The following is a description of a gene set: Human Gene Set: ETS_Q4 studied in species Homo sapiens Genes having at least one occurrence of the motif ANNCACTTCCTG in the regions spanning 4 kb centered on their transcription starting sites. This matches the ETS1 transcription factor binding site V$ETS_Q4 (v7.4 TRANSFAC)., and this is the list of marker genes: TGFB3, CNOT10, CANX, PPP1R9B, NME2, GAB2, ARAP1, CD247, GJA5 (NCBI Gene Id 2702), TEAD3, ACSL5, TNS2, VAV1, ELMO1, CSAD, ZMYND8, DAB2IP, KLF13, CORO1A, DOCK11 (NCBI Gene Id 139818), UXT, ERCC1, ITPR1, HM13 (NCBI Gene Id 92622), PRKAG1, PIK3R4, RAB43, BAZ2A, ARHGAP4, AP1G2, ST7L, SOX14, MAP4K1, SCN2A, CD79A, DDX23, ARPC1B, RGS3, ZBTB41, FOXP1, TAF8, TCF12, E2F3, NHERF1, TIMP4, FURIN (NCBI Gene Id 5123), FOXO3, SLC46A3, RBMS2, KMT2A, STRBP, OMA1, CHMP1B, CAST, HBEGF, PYM1, YRDC, FOXN3, PLA2G4F, HYAL2, YIPF2, ADAMTS4, POLD4, PDGFB, JUNB, PEG10, RLIM, GPR150, KLF12, MTMR12, PML, TMEM185A, BAG4, LSM1, CYTOR, ZBTB7A, ITPRIPL1, IRAK4, CCL2, KDM6A, NASP, USP3, NR1D1, NIPBL, ACTR3, LRFN4, CCDC85B, NDUFS2, PCDH7, TREML2, SEPTIN1 (NCBI Gene Id 1731), ITPR2, DDIT3, PLCB2, HCST, ZNF800, ZFP91, RIN3, RIN1, TBC1D10C, STAT5B, LCP2, ARHGAP30, DPPA4, TCERG1, PAX6, RINL, ARHGAP15, ELK3 (NCBI Gene Id 2004), GDPD5, AGPAT1, ESM1, SKAP1, DGKZ, ARRB2, PPP1R14C, CAP1, VCAM1 (NCBI Gene Id 7412), PTK2, FXYD5, ARSB, RIPOR1, STARD13 (NCBI Gene Id 90627), ERG, BIN3, CNKSR1, DGKA, SOST, LIME1, ITGA11, FGFR2, PDAP1, POU3F4, GMPR2, TWIST1, TNFSF11, SOX2, NCR3, MED26, FOXRED1, GFI1, GATA3, CYB5R4, ADCY4, SEC61A1, RUNDC3A, SIGIRR, SUCNR1, CD2BP2, UBE2L3, GGNBP2, GMFG, EXTL2, FCHO1, RPL41, AGAP2, NEDD8, CALM2, SLC30A7, LTBR, HOXC4, DMTF1, CRADD, LCP1, PPP1R16B, MGAT4A, ACSL4, MARK1, HCLS1, SCN3A, PUS7L (NCBI Gene Id 83448), TMEM256, SND1, PTPN11, RAE1, PKN1, ETF1, KCNAB2, GGT7, HMGA1, ZNF687, MMP3, TRIM41, BLNK, LIF, EGFLAM, TIMM29, MAP7D1 (NCBI Gene Id 55700), RGS14, RAP2C, SPNS3, ZMAT3, MAP4K2, EIF3K, KDF1, CHIC2, SLC9A9, TSHZ3 (NCBI Gene Id 91672), HOXA1 (NCBI Gene Id 3198, homeobox A1), LPCAT4, IL13, C1orf122, ACAP1, MAP9, LSR, POF1B, DRP2, CHD2, NDUFA4, ZNF296, CMTM6, TRMT2B, LYN, PDLIM2, HOXA10, SEC24C, NFKBID, SPIB, ZC3H10, AMD1, RHOV, MADD, SRPRA, BUD31, LIMD2, RBM4, CAPZA1, IKBKB, CD248, LINC03040, SLC41A1, LPXN, CPNE8, NIPAL3, TPP2, SEMA4C, RPS3, TMEM204, KIF3B, ZNF35, DPP3, CBFA2T3, EPN3, E2F5 (NCBI Gene Id 1875), ARHGAP45, NEDD4 (NEDD4 E3 ubiquitin protein ligase), C22orf15, LANCL3, WDR11, ITGB7, ETV5, IL11RA